The following is a description of a gene set: Mouse Gene Set: GOBP_AMINO_ACID_ACTIVATION species: Mus musculus The modification of an amino acid to an active form, for incorporation into a peptide, protein or other macromolecule., and this is the list of marker genes: Wars2, Aars1, Aasdh, Vars1, Lars2 (NCBI Gene Id 245051), Rars1, Hars2, Sars2, Hars1, Sars1, Farsa, Yars2, Gatb, Mars2, Cars2, Rars2, Mars1, Cars1, Nars1, Aars2, Lrrc47, Nars2, Iars1, Dars1, Pars2, Iars2 (NCBI Gene Id 96888), Tars1, Vars2, Kars1, Fars2, Gars1, Wars1, Farsb, Dalrd3, Eprs1, Aarsd1, Dars2, Qrsl1, Yars1, Tars3, Tars2, Lars1, Qars1, Gatc, Ears2